Given this list of marker genes Hspa1b, Hspa1a, Fos, Zfp36l2, Klf2, Klf6, Uba52 (NCBI Gene Id 56512), here is a description of the gene set: from publication Cui A, Huang T, Li S, Ma A, Pérez JL, Sander C, Keskin DB, Wu CJ, Fraenkel E, Hacohen N (PMID 38057668) Genes negatively differentially expressed in cell type: CD8+ T cell upon treatment with cytokine: IFN-κ in mouse lymph nodes in vivo. studied in species Mus musculus Cytokines mediate cell-cell communication in the immune system and represent important therapeutic targets. A myriad of studies have highlighted their central role in immune function, yet we lack a global view of the cellular responses of each immune cell type to each cytokine. To address this gap, the authors created the Immune Dictionary, a compendium of single-cell transcriptomic profiles of more than 17 immune cell types in response to each of 86 cytokines (>1,400 cytokine-cell type combinations) in mouse lymph nodes in vivo. A cytokine-centric view of the dictionary revealed that most cytokines induce highly cell-type-specific responses. For example, the inflammatory cytokine interleukin-1β induces distinct gene programmes in almost every cell type. A cell-type-centric view of the dictionary identified more than 66 cytokine-driven cellular polarization states across immune cell types, including previously uncharacterized states such as an interleukin-18-induced polyfunctional natural killer cell state. Mouse Gene Set: CUI_T_CELL_CD8_IFNK_RESPONSE_DN